Given this list of marker genes CYBC1, CTLA4, IL21 (NCBI Gene Id 59067), SYK, FNIP1, INAVA, NOD2, DOCK11, XIAP (NCBI Gene Id 8257, X-linked inhibitor of apoptosis), PSTPIP1, IL10RA, MEFV, BACH2, IL6, PI4KA, CARD10, GUCY2C, here is a description of the gene set: Crohn's disease Human Gene Set: HP_CROHN_S_DISEASE species: Homo sapiens A chronic granulomatous inflammatory disease of the intestines that may affect any part of the gastrointestinal tract from mouth to anus, causing a wide variety of symptoms. It primarily causes abdominal pain, diarrhea which may be bloody, vomiting, or weight loss, but may also cause complications outside of the gastrointestinal tract such as skin rashes, arthritis, inflammation of the eye, tiredness, and lack of concentration. Crohn's disease is thought to be an autoimmune disease, in which the body's immune system attacks the gastrointestinal tract, causing inflammation.